The following is a description of a gene set: species: Homo sapiens Human Gene Set: DESCARTES_FETAL_HEART_CARDIOMYOCYTES Marker genes curated from the annotated cluster as represented in the Descartes Human Gene Expression During Development database. from publication Cao J, O'Day DR, Pliner HA, Kingsley PD, Deng M, Daza RM, Zager MA, Aldinger KA, Blecher-Gonen R, Zhang F, Spielmann M, Palis J, Doherty D, Steemers FJ, Glass IA, Trapnell C, Shendure J (PMID 33184181) The gene expression program underlying the specification of human cell types is of fundamental interest. The study authors generated human cell atlases of gene expression and chromatin accessibility in fetal tissues. For gene expression, the study authors applied three-level combinatorial indexing to >110 samples representing 15 organs, ultimately profiling ~4 million single cells. The study authors leveraged the literature and other atlases to identify and annotate hundreds of cell types and subtypes, both within and across tissues. Our analyses focused on organ-specific specializations of broadly distributed cell types (such as blood, endothelial, and epithelial), sites of fetal erythropoiesis (which notably included the adrenal gland), and integration with mouse developmental atlases (such as conserved specification of blood cells). These data represent a rich resource for the exploration of in vivo human gene expression in diverse tissues and cell types., and this is the list of marker genes: FABP2, EPN3, BVES-AS1, PDE4DIPP1, ENSG00000232939, UGT2B4, HRAT17, PRSS42P (serine protease 42, pseudogene), RNA5SP327, CSNK1A1P1, HHATL, MYPN, BMP10, LINC02248